Given this list of marker genes MAN2B1, EDC4, CDH11, FOXM1, SEMA4D (NCBI Gene Id 349236), LGALS3BP, POMZP3, SNX19, NNMT, FZD2, ELAVL1, CD14, CD68, PDXK, LGMN, COL1A2, PLD3, C5AR1, SKIC2, GNA15 (NCBI Gene Id 2769), WASF3, LTF, DRP2, NRG1, EYA2, DOK1, ATP1B1, TOB1, TBXAS1, CCR1, SOD2, SLAMF1, IL2RB, RAB31, ACR, DEFA1, GRK5, S100A9, AOAH, CBR1, FXYD3, MT2A, TNNI2, FOLR2, DUSP2, TAX1BP3, DGCR2, PLOD1, TRIO, HNF1A, NINJ1, IFI27, MT1H, HBEGF, MYL9, CDK10, CYP27A1, KDM5C, LPCAT3, CP, TRIP10, DNM2, ORM1, VIPR2, P2RX4, GDF15, MGAT1, MAT1A, TLR1, GRB7, TARBP2, C3AR1, SECTM1, PIEZO1, IER3, S100A1, THBS4, FN1, SAA1, MMP12, HLX, LAG3, MYLK, PPP5C, ETS1, DHCR24, DNTT, SUPT5H, PPIB, AGXT, PRRX1, POSTN, SPI1, CSF3R, ENG, here is a description of the gene set: Genes in the cancer module 174. Human Gene Set: MODULE_174 species: Homo sapiens